Given this list of marker genes Ephx2, Acp3, Acp6, Plppr4, Plpp1, Plpp6, Plppr1, here is a description of the gene set: species: Mus musculus Catalysis of the reaction: lysophosphatidic acid + H2O = phosphate + monoacylglycerol. Mouse Gene Set: GOMF_LYSOPHOSPHATIDIC_ACID_PHOSPHATASE_ACTIVITY